The following is a description of a gene set: studied in species Homo sapiens Reactome Pathway: Defective SLC40A1 causes hemochromatosis 4 (HFE4) (duodenum) part of: SLC transporter disorders The primary site for absorption of dietary iron is the duodenum. Ferrous iron (Fe2+) is taken up from the gut lumen across the apical membranes of enterocytes and released into the portal vein circulation across basolateral membranes. The human gene SLC40A1 encodes the metal transporter protein MTP1 (aka ferroportin or IREG1). This protein resides on the basolateral membrane of enterocytes and mediates ferrous iron efflux into the portal vein. SLC40A1 colocalises with hephaestin (HEPH) which stablises it and is necessary for the efflux reaction to occur.<br>Defects in SLC40A1 can cause hemochromatosis 4 (HFE4; MIM:606069), a disorder of iron metabolism characterised by iron overload. Excess iron is deposited in a variety of organs leading to their failure, resulting in serious illnesses including cirrhosis, hepatomas, diabetes, cardiomyopathy, arthritis and hypogonadotropic hypogonadism. Severe effects of the disease don't usually appear until after decades of progressive iron overloading (De Domenico et al. 2005, 2006, 2011, Kaplan et al. 2011)., and this is the list of marker genes: HEPH (hephaestin), SLC40A1